The following is a description of a gene set: Binding to a MutSalpha mismatch repair complex. studied in species Homo sapiens Human Gene Set: GOMF_MUTSALPHA_COMPLEX_BINDING, and this is the list of marker genes: PMS2 (PMS1 homolog 2, mismatch repair system component), MLH1, TREX1, ATR, MUTYH, MCM9, MCM8